Given this list of marker genes AWAT2, RLBP1, RBP3, OPN1LW, OPN1MW, DHRS3, OPN1SW, here is a description of the gene set: part of: Visual phototransduction Rods and cones share the same mechanism for the phototransduction process but perform functionally different roles. Although cone photoreceptors make up around 5% of all photoreceptor cells and are outnumbered 20 to 1 by rod photoreceptors, they mediate daylight vision in the human eye whereas rods mediate twilight vision. Also, cones are around 100-times less light-sensitive than rods thereby depriving us of colour vision in dark conditions in which cones cannot function. Rod function saturates in even moderate amounts of light whereas cones can adjust to even very bright light conditions, a process called light adaptation. In bright conditions, rods can take up to one hour to regain their sensitivity whereas cones can recover in a few minutes, a process called dark adaptation and which allows us to retain visual perception in changing light conditions.<br><br>Cone cells express three types of opsin which allow colour discrimination. Long Wavelength Sensitive Opsin (OPN1LW) detects red, Short Wavelength Sensitive Opsin (OPN1SW) detects blue, and Medium Wavelength Sensitive Opsin (OPN1MW) detects green regions of the light spectrum.<br><br>In the canonical retinoid (visual) cycle, the visual chromophore is regenerated in reactions involving the rod outer segments (ROS) and the retinal pigment epithelium (RPE). For cones, chromophore recycling is independent of the RPE and instead involves Muller cells in the retina which supply the chromophore selectively to cones. The molecular steps of the cone retinoid (visual) cycle are outlined in this section. The ability of cones to react to bright and differing light conditions means it has to regenerate the chromophore much quicker than rods. All-trans-retinol (atROL) released from cone outer segments is taken up by Muller cells where it is directly isomerized back to 11-cis-retinol (11cROL) then esterified by LRAT. When required, these 11-cis-retinyl esters can be hydrolysed by 11-cis-RE hydrolases back to 11cROL then oxidised in the cone photoreceptor cell to regenerate 11-cis-retinal (11cRAL), the visual chromophore (see reviews von Lintig 2012, Wang & Kefalov 2011, Kefalov 2012, Wolf 2004). Reactome Pathway: The retinoid cycle in cones (daylight vision) species: Homo sapiens